Given this list of marker genes Cdc27 (NCBI Gene Id 268493), Cdc26, Cdc16, Ube2srt, Anapc1, Anapc15, Cdc23, Anapc2, Anapc5, Aurkaip1, Ube2c, Anapc16, Rbx1, Cdc20b, Anapc13, Fzr1, Cdc20, Anapc15-ps, Ube2s, Anapc7, Anapc10, Mad2l2, Anapc4, Anapc11, here is a description of the gene set: A ubiquitin ligase complex that degrades mitotic cyclins and anaphase inhibitory protein, thereby triggering sister chromatid separation and exit from mitosis. Substrate recognition by APC occurs through degradation signals, the most common of which is termed the Dbox degradation motif, originally discovered in cyclin B. Mouse Gene Set: GOCC_ANAPHASE_PROMOTING_COMPLEX studied in species Mus musculus